Given this list of marker genes FGF8, CRKL, PAX6, BMP2 (bone morphogenetic protein 2), WNT5A, DKK3, CLOCK, RFX6, HESX1 (HESX homeobox 1), AKT1, EIF2AK3, GLI1, NR5A1, FGF10, MNX1, SRD5A1, SOX4, NKX2-2, IL6R, GSK3B (NCBI Gene Id 2932), BAD, WNT4, PDX1, TUBB1 (tubulin beta 1 class VI), NR3C1, BAK1, HIPK2, CDK6, GIPR, HOXA3, TBX1, ALDH1A2, HES1, NKX6-1, GSX1, POU3F2, GSK3A, MSX1, NR0B1, NF1, ONECUT2, IER3IP1, ISL1, EDN1, BRAF, GHRHR (NCBI Gene Id 2692), SALL1, CRHR1, PAX8, FOXE1, NKX6-2, CDH1, TSPO, MAPK3, SHH, HOXB3, POU1F1, SIX3, PBX1, SIDT2, GDF11, WT1, PDGFRA, SMAD4 (SMAD family member 4), OTP, GATA3, BMP4, SMO, MAP2K2, MDK, SOX9, GCM2, IL6, HOXA5, NKX2-5, BMPR1A, MIR541, ONECUT1, ARMC5, EDNRA, INSR, FOXI3, BMP5, CRH, ASCL1, RHEB, TG, MAP2K1, CDKN1C, RAF1, SIX1, RAP1GAP, PITX1, THRA (NCBI Gene Id 7067), HMGA2, WNT11, CDH2, HNF1B, BMP6, NOG, HOXD3, FGF2, GATA2, DRD2, PDPK1, INSM1, SMAD3, GLI2, SLC6A3, PROP1, GATA6, FOXA2, NEUROD1, TGFBR1, APOA1, CITED2, RFX3, DLL1, SOX3, CGA, SOX2, LHX3, RBPJ, GHRH, CREB1, INHBB, BMAL1, ARID5B, NKX2-1, TBX19, ZNF800, BHLHA15, PAX4, STRA6, SRF, GIP, MAPK1, PITX2, here is a description of the gene set: Human Gene Set: GOBP_ENDOCRINE_SYSTEM_DEVELOPMENT species: Homo sapiens Progression of the endocrine system over time, from its formation to a mature structure. The endocrine system is a system of hormones and ductless glands, where the glands release hormones directly into the blood, lymph or other intercellular fluid, and the hormones circulate within the body to affect distant organs. The major glands that make up the human endocrine system are the hypothalamus, pituitary, thyroid, parathryoids, adrenals, pineal body, and the reproductive glands which include the ovaries and testes.